The following is a description of a gene set: Genes predicted to be targets of miRBase v22 microRNA hsa-miR-10393-5p in miRDB v6.0 with MirTarget v4 prediction scores > 80 (high confidence targets). Human Gene Set: MIR10393_5P from publication Chen Y, Wang X (PMID 31504780) species: Homo sapiens, and this is the list of marker genes: USP22, RGS20, BICD2, LRIF1, ARL13B, STT3B, HNRNPU, FCRL2, ZFP1, MBD1 (NCBI Gene Id 4152), ZNF382, MARVELD3, POLD3, CYP2U1, MYEF2, ZNF514, JADE1, CEP126, CEP128, ZNF229, PAPOLB, ZFP90, CEP44, PIAS1, ZNF347, HNRNPA0, ZNF568, SIKE1, TARDBP, SMAP1, C1orf52 (NCBI Gene Id 148423), BEND7, ADAMTS3, MAPK8, RANBP3L, DLX5, DNTT, ZNF37A, ZNF594, GIPC2, KRBOX4, ZNF780B, ZNF781, RERG, GIN1, IDH3A, GFRA1, KPNA1, PIP4P2, RAPGEF4, COL4A1, ZNF532, RC3H1, SLC10A2, EMB, GRM5, DENND1B, RBM39, ZNF322, LRRTM4, FAR2, AVL9, ZNF765, ZNF711, NONO, CYCS, ERC1, ZNF268, TMEM265, ZNF117, TXNDC17, MMP20, RAB28, IL6ST, SLC47A1, YIPF4, CERT1, CAMK4, FUT9, ZSCAN12, CA8, GPR180, ZNF676 (NCBI Gene Id 163223), MSANTD3, SLC40A1, SPINK5, FBXO47, BTG1, UBE2V2, SLF2, FAM107B, KLF6, ADAM7, UNKL, CNST (NCBI Gene Id 163882), CCDC71L, SAMHD1, RAB39B, C2CD6, NBEA, COL17A1, ZNF208, LBR, RBM18, CTTN, EXOC5, DISC1, ZNF28, PIGR, ZNF813, ZNF233, ZNF195 (zinc finger protein 195), TMPRSS11A, ACKR4 (atypical chemokine receptor 4), ARRDC2, ABL2, JAM2, RREB1, ZNF189, MCUR1, MYOF, RAB27B, HTR2C, ZNF816, TBC1D25, PDPK1, UCP3, ZNF302 (NCBI Gene Id 82167), SMIM8, LPP, CNOT6L, SIX4, ANOS1, ZNF684, TBC1D9, SEMA6A, PLCXD3, ZNF544 (zinc finger protein 544), ZNF468, PTK2, MFSD6, THEMIS, ZNF761, WDFY2, MEX3B, NRIP1, CNTLN